Given this list of marker genes ABCF3, ST8SIA3 (NCBI Gene Id 83169), BAG4, DYNC1LI2, SALL4, TUBA4A, QKI, RELN, PDK4, TMEM100, SLC2A14, RAD50, IKBKB, UBQLNL, ZCCHC3 (zinc finger CCHC-type containing 3), ILDR2, SMIM13, SPRYD3, KRTAP11-1, SYNRG, EZH1, ARMCX2, FGFR1 (fibroblast growth factor receptor 1), MOB4, CPEB3, MED26, FBXO21, CPEB2, CCDC88C, MYLK, RBBP6, SAV1, DRD1, NR2C2, MCU, CCND1, BTAF1 (B-TFIID TATA-box binding protein associated factor 1), AMMECR1, UBE2Q1, CBX6, NUP50, TMEM183A (NCBI Gene Id 92703), RS1, MTFR1L, PLXNC1, SNRPB2, MOB3B, NRN1, FERMT2, SLC35G1, TRAM1, ANO3, CYP26B1 (NCBI Gene Id 56603), TMEM154, CLOCK, AXIN2, CACNA1E, CHEK1, RAB30, HIPK2, ATF6 (NCBI Gene Id 22926), FBXW7, ACTR2, C1orf21, P3H2, ARHGAP12, RNF217, GNAT1, NFATC3, SOBP, FAM135A (family with sequence similarity 135 member A), CC2D1B, SYNJ1, CDC42SE2, APLN, KCNN4, RSPO3, ATXN7L1, COPS7B, CNOT6L, MFN2, HTR2A, SEMA6D, CBX2, ATG13, LGR5, ST7L, USP25, YTHDC1, TRABD2B, PPP1R11, ARIH1, TLK1, ARHGDIA, GHR, OGT, CSDE1, MAP3K13, SON, STOX2, WNT3A (Wnt family member 3A), CHPT1, CREBRF, ATG9A, PLRG1, EYA1, STXBP3, SCOC, TBL1XR1, MAMSTR, GPR63, SESN1, CDC37L1, PLXNA4, TFCP2L1, CPD, PPM1E, ARFGAP2, SLC25A37, ANKS1A, C1QL3, COP1, SSTR3, PTPN3, FAM110C, ADRB2, FGF7, CASK, UNC80 (NCBI Gene Id 84540, unc-80 homolog, NALCN channel complex subunit), PDE3B, ADAMTS3, CCNT1, ANKUB1, RBPJ, SNTB2, AGO4, TAB3, NF1, DENND2C, NCS1, RASEF, NSG1, BZW1, EPC1, DDX3X, PCDH9, GALNT7, TMEM199, ELL, SOX6, SLC9A6, CPSF7, CACUL1, SMURF2, GPATCH8, AKT3, TCAIM, TBPL1, KIF5C, BTG2, CASR, UBE4A, EDA, RBM12, MASP1, TMEM178B, ATXN7L3B, ZMYM2, ATG14, UNC5D, PIK3R1, RAB11FIP2, JPH3, CFAP45, HSPA4L, COL12A1, CEP85L, LRRN3, VPS4A, CDK5R1, C2orf42, IVNS1ABP, PPP2R1B, RAB9A, NECTIN1, USP31, TMEM245, FAM133B, N4BP1, LRIG1, MKNK1, CD47, SUCO, CCNE1 (NCBI Gene Id 898), ACVR2B, COBLL1, AK4, ZDHHC15, DMTF1, TGIF2 (TGFB induced factor homeobox 2), ANXA11, PTPRD, MTMR3, KLHL2, MYEF2, ADGRL1, USP42, USP15, SLC13A3, PABIR2, WNK3, KIF23, ARL2, ZNHIT6, WIPI2, HSPG2, PTPRR, CMC4, MAN2A2, PDZD8, SEL1L3, LRIG2, SNX16, CDCA4, AMER1, ZFHX3, EGLN1, TMEM135, SPTLC1, SOCS6 (NCBI Gene Id 9306), GFAP, SALL1, ETNK1, UBFD1, DNAJB4, KANK1, SMURF1, GSTCD, C12orf76, GGA3, SLC39A9, GLS2, ANKRD46, PEDS1-UBE2V1, TARBP2, AMOTL1, SYT4, RET (NCBI Gene Id 5979), NRP2, NOS1, DLL1, ZBTB46, TRIM66, JARID2, ZC2HC1A, ARMH4, INSR, DCP1A, RETREG2, KIF1B, KCNG4, PCDH17, MYO5B, SRPRA (NCBI Gene Id 94501), TFAP2A, NAA25, FOXK1, PPT2, HELZ, IARS1, SLC36A1, SEMA3A, CLUH, ZBTB39, CDK8, NSMF, LAMC1, OOEP (oocyte expressed protein), DENND1B (NCBI Gene Id 54530), DCLK1 (NCBI Gene Id 9201), GRM7, RNF10, PNPLA6, CUX1, AHCYL2, XPO7 (exportin 7), PAFAH1B1, SHOC2, STK33, RPS6KA3, ZSCAN31, KIF3B, PPM1A (NCBI Gene Id 5494), RICTOR, PCMT1, MKX, LUZP1, NAV1, CYB561A3, MGAT4A, PIP4P1, ZBTB20, UNC13A, SLC4A4 (NCBI Gene Id 8716), SPRED1, ATXN2 (NCBI Gene Id 8095), KDSR, SIK1, PHF19, OTX1, ZCCHC2, PISD, BCL2L2, LAMP3, EPHA7, ZC3H13, PDIA6, POU2F1, ARHGAP20, PLAG1, MNT, TRANK1, HEPHL1, RAB9B (NCBI Gene Id 51209), VPS33B, PEX13 (peroxisomal biogenesis factor 13), STXBP5, CXCR5 (NCBI Gene Id 643), USP44, CDK17, AMOT, EPHB2, GABARAPL1, RAD23B, ZNRF3, DMPK, MAP3K9, PARVA, LARGE2, FAM91A1, WBP11, PPP6R3, RASSF8, ISLR, PTPN4, RBM6, CSRNP1, CAPRIN1, SLC11A2, PAFAH1B2, RASGEF1B, UTP25, ZNF691, DDX3Y, ENAH, VEGFA, SLC20A2, KIF1C, IPO7, LURAP1L (leucine rich adaptor protein 1 like), CARM1, SUMO3, ZNF449, RPS6KA6, PELI2, WWC1, RFX3, HERC6, DYRK1B, PTH, DEPDC4, ASH1L, BCL11B, ACVR2A (activin A receptor type 2A), CEP55, SETD3, ELAC1, MEOX2, NAPG, HMGA1, PIP4P2 (phosphatidylinositol-4,5-bisphosphate 4-phosphatase 2), SLC12A2, CHUK, SREK1, MIDEAS, MYO5A, SSR1, HTR4, FAM81A, CAPZA2, G2E3, ATXN1L, SLC6A11, SGK1, ROCK2, SKI, RECK, LSM11, SERBP1, RFK, KCTD8, ARHGAP32, LITAF, ZNF367, CHIC1, ATXN7L2, SYPL1 (NCBI Gene Id 6856), SLIT2 (slit guidance ligand 2), SH3GL2, MYBL1, LRP2, ENSG00000275993, PLPP1, WEE1, LRP6, BTRC, TGFBR3, SEC24A (NCBI Gene Id 10802), ACOX1, SYT3, GALNT13, CBX4, IFT74, KIF21A, RUNX1T1, PAPPA, KCNK10, SPTBN2, CCDC6, TLL1 (tolloid like 1), HMBOX1, MEX3C, TSC22D2, RBM24 (NCBI Gene Id 221662), PIAS2, KRTAP4-6, CD2AP, ABHD2, CYP2S1, OMG, GAREM1, E2F3, ZBTB44, KIF5B, ZNRF2, SAMD10 (sterile alpha motif domain containing 10), CLCN4, HECTD1, AGO1, SIPA1L2, PRDM4, USP3, DESI1, UBN2, UBE4B, UROS, SEPTIN2, FASN, ARL3, GATAD2A, TNRC6B, NUFIP2, CDC25A, ABL2, LDLRAD2, ATXN7L3, IGF2R, AVL9, CHAC1, SEH1L, LATS1, TBP (TATA-box binding protein), NOB1, RUNDC3B, SIRT4, ZFHX4, GCC2, NHLRC2 (NHL repeat containing 2), EXOC3L2, RNF144B, LRRK1, CMPK1, SLC39A10, STRADB, MAP2K1, FBXL20, TMEM268, TMCC1, SCN8A, ZNF622, FLT3, SEMA5B, WNT7A, CD3E, SMAD7, DIXDC1, TMC7, DPY19L4 (NCBI Gene Id 286148), PAG1, KCNJ2 (NCBI Gene Id 3759), MYB, CHD2, RARB, SYDE2, PRRC2C, TENM2, CD80, TNFSF13B, CACNA2D1, ZMAT3, FAM89A, CCND2, UBE2V1, ZBTB34, HIGD1A, RREB1, YWHAH, IPPK, FGF2, here is a description of the gene set: Genes predicted to be targets of miRBase v22 microRNA hsa-miR-497-5p in miRDB v6.0 with MirTarget v4 prediction scores > 80 (high confidence targets). from publication Chen Y, Wang X (PMID 31504780) studied in species Homo sapiens Human Gene Set: MIR497_5P